Given this list of marker genes Smc2, Tet2, Ece1, Klf8, Capza1, Morc3, Atg4c, Kif20a, Kcnj3, Suv39h2, Prkd1, Stxbp5, Vegfc, Hspb9, Vps37a, Zfp503, Gtf2e1, Tbc1d12, Rpl22, Ipo5, Ube2g1 (NCBI Gene Id 67128), Cd82, Rprd1a, Rasef, Zc3h7b, Syap1, Herc6, Hook3, Gpbp1l1, Zfp286 (zinc finger protein 286), Ntng1, Xrn1, Nsd2, Gpr85, Ccng2, Tgfa, Ank3, Eif1b (NCBI Gene Id 69266), Ankib1, Samd8, Sec23ip, Slc6a1, Eif3a, Ptx3, Fam227a, Cyfip1, Itgav, Mbnl2, Setd2, Tmx3, Tmem263, Myh10, Atl2, Cxadr, Fam91a1, Ccr4, Smpd3, Tbc1d8b, Bmpr2, Ddx3x, Siah1a, Siah1b, Ikzf2, Impact, Tob1, Lrch2, Pcdh19, Ocln, Bptf, Ivd, Arid2, Zfp512b, Syde2, Tmem158, Tvp23b, Trp53inp1, Taok1, Sec23a, Atraid, Cdk17 (cyclin dependent kinase 17), Ube2e3, Slit2, Rilpl2, Tbx22, Mob4, Pttg1, Tmem200c, Nectin1, Wasf3, Atxn7, Fchsd2, Zfand5, Cd160, Cnrip1, Grpel2, Adgrl2, Kctd21, Mbnl3, Nectin3, Nup93, Rbm24, Prl7a2, Fam76b, Mbtd1, Prelid3b, Grm3, Zmynd8, Mgat4c, Nucks1, Senp6, Sestd1, Pnpt1, Epb41l2, Frmd4a, Ubn2, Gopc, Prpf4, Clec12a, Glod4, 4930447C04Rik, Tasl, Dhx15, Pcdh7, Snrpf, Sinhcaf, Sp8, Nup160, Slc6a20b, Gnai3, Ccnyl1, Srf, Zfp236, Trib2, Egr1, C1galt1c1, Slc26a11, Cdh2, Dock9, Snrnp40, Zfp711, Smco3, Fhip2a, Kdm5a, AU015228, Nab1, Tpmt, Cnr1, Scamp1, Phtf2, Nipbl, Adcy5, Spin4, Nf1, Slc13a4, Rab10, Ctdspl2, Vegfa, Epha4, Cyfip2, Cebpb, Acta2, Stk38l, Sema3e, Kdm7a, Cd200, Nxt2, Greb1l, Acsl4, Atp5mc2, Braf, Senp7, Ythdc2, Adam10, Nfib, Tmem38b, Smad2, Gpr162, Tmem168 (transmembrane protein 168), Ppig, Zcchc24, Map7, Dcn, Fermt2 (fermitin family member 2), Macf1, Ubl3, Ids, Irx5, Tbl1xr1, Adamts6, Map4, Art3, Pou4f2, Trim62, Bicd2, Crebzf, Brs3, Thap1, Calcb, Akirin2, Apc (APC, WNT signaling pathway regulator), Cpeb3 (NCBI Gene Id 208922), Map2k4, Nlrp4b, Numbl, Wee1, Elovl5, Cask, Rlim, Gpc6, Ror1, Cep350, Adm, Flrt3, Crispld1, Plg, Maip1, Tle4, Sema5a, Tmem117, Trdmt1, Per2, Scoc, Ascl1, Lgalsl, Vezf1, Rab2a, Dlx4, Clcf1, Zfp281, Srsf1, Lrrc32, Gas7, Tenm3, Ddx3y, Sdhc, Kcnj13, Tm4sf20, Gm6377, Bmp3, Pou4f1, Mef2a, Tcf7l2 (transcription factor 7 like 2, T cell specific, HMG box), Lmo4, Zfp36, Spred1, Peg10, Arap2, Srsf5, Il18r1, Tob2, Prrx2, Tubal3, Rnf130 (NCBI Gene Id 80609), Bhlhe22, Arid4b, Ermn, Slc7a5, Clic4, Gprc5b (G protein-coupled receptor, family C, group 5, member B), 1110004F10Rik, Ino80d, Ythdf1, Fndc3b, Kpna6, Spink11, Fbxl20, Plcxd3, Ciapin1, Dph7, Cmtr2, Kctd1, Sfpq, Ubiad1, Gpm6a, Jkamp, Ciao1, Dmd, Ccnc, Ppp4r3b, Flg2, Syt4, Hhip, Mettl21c, Scyl3, Rasgrf1, here is a description of the gene set: Mouse Gene Set: MIR_374C_5P studied in species Mus musculus from publication Chen Y, Wang X (PMID 31504780) Genes predicted to be targets of miRBase v22 microRNA mmu_miR_374c_5p in miRDB v6.0 with MirTarget v4 prediction scores > 80 (high confidence targets).